The following is a description of a gene set: electronically inferred by orthology from the curated human pathway This event has been computationally inferred from an event that has been demonstrated in another species.<p>The inference is based on the homology mapping from PANTHER. Briefly, reactions for which all involved PhysicalEntities (in input, output and catalyst) have a mapped orthologue/paralogue (for complexes at least 75% of components must have a mapping) are inferred to the other species. studied in species Mus musculus part of: Resolution of AP sites via the multiple-nucleotide patch replacement pathway Reactome Pathway: PCNA-Dependent Long Patch Base Excision Repair, and this is the list of marker genes: Pole, Rfc3, Pold4, Rpa1, Lig1, Pold2, Pold1, Pcna, Rfc1, Apex1, Pole2